The following is a description of a gene set: The process in which the cellular identity of muscle cells is acquired and determined. Human Gene Set: GOBP_MUSCLE_CELL_FATE_COMMITMENT studied in species Homo sapiens, and this is the list of marker genes: MYOG, MEF2C, MYF5, FGF10, TBX3, MYL2, TBX5 (T-box transcription factor 5), MYF6, MIR19B1, TBX18, TBX1, TBX2, ACVR1, WNT3A, NKX2-5, WT1, MYOD1